The following is a description of a gene set: This event has been computationally inferred from an event that has been demonstrated in another species.<p>The inference is based on the homology mapping from PANTHER. Briefly, reactions for which all involved PhysicalEntities (in input, output and catalyst) have a mapped orthologue/paralogue (for complexes at least 75% of components must have a mapping) are inferred to the other species. electronically inferred by orthology from the curated human pathway species: Mus musculus part of: Regulation of CDH1 Expression and Function Reactome Pathway: Regulation of CDH1 posttranslational processing and trafficking to plasma membrane, and this is the list of marker genes: Pcsk7, Spcs2 (NCBI Gene Id 66624), Stt3a, Spcs1, Sec11c, Pomt2, Prkcsh, Csnk2b, Ctnnb1, Ddost, Dad1, Cdh1, Jup, Tmem258, Pip5k1c, Spcs3 (NCBI Gene Id 76687), Ganab, Ost4, Pomt1